The following is a description of a gene set: The growing (plus) end of a microtubule. In vitro, microtubules polymerize more quickly at the plus end than at the minus end. In vivo, microtubule growth occurs only at the plus end, and the plus end switches between periods of growth and shortening, a behavior known as dynamic instability. Mouse Gene Set: GOCC_MICROTUBULE_PLUS_END studied in species Mus musculus, and this is the list of marker genes: Mapre3, Clip1, Spag5, Dctn1, Knstrn, Kif3c, Slain1, Kif18b, Kif2c, Clip3, Clip4, Tbcb, Gas2l2, Gas2l1, Clasp2, Nckap5, Dst, Nckap5l, Mapre1, Slain2, Clip2, Numa1, Mapre2, Cdk5rap2, Pde4dip, Ckap5